The following is a description of a gene set: Genes predicted to be targets of miRBase v22 microRNA mmu_miR_3475_3p in miRDB v6.0 with MirTarget v4 prediction scores > 80 (high confidence targets). from publication Chen Y, Wang X (PMID 31504780) Mouse Gene Set: MIR_3475_3P studied in species Mus musculus, and this is the list of marker genes: Coprs, Xcr1, Fhl1, 4933412E24Rik, Phf21a, Aak1, Slc25a37, Syp, Krt5, Card11, Sh3pxd2b, Kremen1, Rbm33 (NCBI Gene Id 72420), Dop1a, Mgat5b, Scimp, Madd, Shisa6, Smarcad1, Nhsl2, Sypl2, Mmp15, Hhipl2, Dpm2, Arpc5, Slc1a1, Pla2g5, S100a16 (S100 calcium binding protein A16), Zfp747l1, Rgs16, Bcl9l, Alpk1, Usp18, Pnck, Plxnc1, Dlx3, Pym1, Sh3bgrl3, Satb2, Phldb2, Matn1, Epsti1, Nfia, Zbtb2, Faim2, Tnfrsf11a, Fam180a (family with sequence similarity 180, member A), Atxn7l2, Pnkd, Galnt10, Lmnb2, Chmp6, Cntn2, Nrsn1, Cuedc1, Gramd2a, Fkbp1a, Slc13a3, Psmf1, Def8, Mtcl2, Slc27a4, Borcs5, Bcat1, Ldlrad3, Cpne6, Itprip, Jph3 (junctophilin 3), Gzmg, Ndst1 (N-deacetylase/N-sulfotransferase (heparan glucosaminyl) 1), Bcl7a, Ankrd11, Tcim, Pcyt1a, Ywhab, Trp53inp1, Hdac10, Cacul1 (NCBI Gene Id 78832), Dtnb, Gzmf, Zmat4, Nfu1, Aifm3, Twf2, Xxylt1, Adarb1, Selp, Cry2, Agap3, Fam20b (NCBI Gene Id 320420), Nol4, St6galnac6 (NCBI Gene Id 50935), Zfand5, Tmem62, B4galt1, Trpc5os, Ccdc177, Adcy5, Sumo2, Hid1, Osm (oncostatin M), Fzd4, Rfx4, Gzmd, Spry2, Scube1, Pars2, Tox3, Gzme, Adrb3, Sap130, Pakap, Zdhhc9, Frat2, Celf5, Gzmn, Ccnh